The following is a description of a gene set: The non-covalent aggregation and arrangement of proteins and lipids to form a high-density lipoprotein particle. Human Gene Set: GOBP_HIGH_DENSITY_LIPOPROTEIN_PARTICLE_ASSEMBLY studied in species Homo sapiens, and this is the list of marker genes: PRKACB, APOE, ABCA7, LCAT, ABCA1, NR1H2, APOA1, PRKACA, APOA2, APOM, ZDHHC8, MIR144, PRKACG